Given this list of marker genes Cacna1e, Hgf, Shisa7, Col5a1, Fstl3, Samd4b, Pi4kb, Spata2, Ceacam2, Syna, Sytl4, Luzp1, Pgap2, Rimbp2, Bak1, Ano1, Rhog, Crtc1, Dagla, Vat1, Cldn3, Scrt2, L1cam, Kcnab2, Plagl2, Dmpk, Hadha, Evc2, Zbtb4, Mlec, Tmem164, Hdac11, Lsm10, Setd1b, Smarcd1, Zbtb22, Cited2, Ctif, Diaph1, Tubg2, Med29, Stum, Rab40c, Car5b, Jup, Scn2b, Mylk2, Phka2, Cluh, Pbx2, Tspan5, Susd6, Itpka, Daam2, Padi2, Aak1, Tom1l2, Prx, Nova2, Ceacam1, Nog, Adam11, Tnrc6a, Cyb5r3, Ints5, Mafb, Stk32b, Zfp316, 1700017B05Rik, Lamc3, Tpcn1, Chst2, Rlig1, Gm4922, Nkx2-2, Spry4, Dlgap1, Carm1, Rgs6, Gnao1, Ndn, Mknk2, Ptpre, Slc48a1, Nfic, Fam222a, Slc6a8, Samd4, Mier2, Ubl7, B3gnt7, Pitpnm2, Csk, Rgp1, Gas7, Ddx10, Zfp609 (NCBI Gene Id 214812), Sdc3, Ralgps1, Smarcc2, Nfasc, Nptxr, Bahcc1, Edem1, Tmem52b, Il22ra1, Eif2s3x, Rabl2, Meis2, Syndig1l, Szrd1, Atic, Smg5, Ago1, Chd3, Nfix, Kirrel1, Slc25a42, Gpr158 (NCBI Gene Id 241265), Kdm4b, Ssbp3, Pdxp, Ski, Kdm2a, Zbtb34, Vegfa, Iqsec2, Phip, Stn1 (NCBI Gene Id 69648), Ptgfrn, Foxp4, Ppp2r5b, Sema5a, Celf5, Diras1 (NCBI Gene Id 208666), Slc6a17, Mdk, Slc13a3, Hivep3, Wnt1, Mllt6, Pip5k1c, Vax1, Mta1, Mamstr, Aplnr, Dpp6, Grb2, 2900026A02Rik (NCBI Gene Id 78676), Rgma, Msi2, Tbx5, Rph3al, Kpna4 (NCBI Gene Id 78766), Emc10, Nav2, Tyw1, Or13e8, Ttc34, Npcd, Zfyve27, Dlk1, Cdk18, Hmga1, Syn3, Elavl3, Islr2, Bcl2l1, Syt7, Cacna1c, Cd300lb, Atp2b4, Spata31d1a, Phospho1, Epha8, Pou2f2, Pou2f1, Fchsd1, Enc1, Bcl7a, Cxcr4, Dnajb5, Ppp1r9b, Lrch4, Sgsm2, Agpat1, Btla, Zrsr2, Ccdc97, Aph1a, Nacc1, Tnks1bp1, Nod2, Myl6b, Tnfsf12, Map3k13, C130050O18Rik, Scube1, Tmsb10, here is a description of the gene set: from publication Chen Y, Wang X (PMID 31504780) Mouse Gene Set: MIR_92A_2_5P studied in species Mus musculus Genes predicted to be targets of miRBase v22 microRNA mmu_miR_92a_2_5p in miRDB v6.0 with MirTarget v4 prediction scores > 80 (high confidence targets).